The following is a description of a gene set: KSRP binds to AU-rich sequences in the 3' untranslated regions of mRNAs. KSRP causes the bound mRNA to be targeted for hydrolysis by recruiting exonucleases and decapping enzymes. The activity of KSRP is regulated by phosphorylation. Protein kinase B/Akt phosphorylates KSRP at serine193. The phosphorylation inhibits the ability of KSRP to destabilize mRNA. KSRP phosphorylated at serine193 binds 14-3-3zeta (YWHAZ) which causes KSRP to be retained in the nucleus. species: Homo sapiens Reactome Pathway: KSRP (KHSRP) binds and destabilizes mRNA part of: Regulation of mRNA stability by proteins that bind AU-rich elements, and this is the list of marker genes: EXOSC2, EXOSC7, MAPK11 (mitogen-activated protein kinase 11), EXOSC6, PARN, EXOSC4, DIS3, EXOSC1, EXOSC5, DCP2, AKT1, KHSRP, YWHAZ, EXOSC8, EXOSC3, EXOSC9, MAPK14